The following is a description of a gene set: Reactome Pathway: Binding of TCF/LEF:CTNNB1 to target gene promoters part of: Formation of the beta-catenin:TCF transactivating complex studied in species Homo sapiens The genes regulated by beta-catenin and TCF/LEF are involved in a diverse range of functions in cellular proliferation, differentiation, embryogenesis and tissue homeostasis, and include transcription factors, cell cycle regulators, growth factors, proteinases and inflammatory cytokines, among others. A number of WNT signaling components are themselves positively or negatively regulated targets of TCF/LEF-dependent transcription, establishing feedback loops to enhance or restrict signaling (see for instance, Khan et al 2007; Chamorro et al, 2005; Roose et al, 1999; Lustig et al, 2002). Other than a few of these general feedback targets (e.g. Axin2), most target genes are cell- and/or tissue-specific. A list of WNT/beta-catenin-dependent target genes is maintained at http://www.standford.edu/group/nusselab/cgi-bin/wnt/target_genes., and this is the list of marker genes: TCF7L2, LEF1, MYC, CTNNB1, TCF7L1, TCF7, AXIN2, RUNX3